The following is a description of a gene set: studied in species Mus musculus Mouse Gene Set: REACTOME_LAMININ_INTERACTIONS Laminin interactions, and this is the list of marker genes: Col4a3, Itga3, Col4a1, Itga7, Col4a5, Itga6, Col4a6, Lama4, Nid2, Col4a4, Col4a2 (collagen, type IV, alpha 2), Megf6, Itgb4, Itgb1, Nid1